The following is a description of a gene set: Catalysis of the reaction: thioredoxin-dithiol + NADP+ = thioredoxin-disulfide + H+ + NADPH. Mouse Gene Set: GOMF_THIOREDOXIN_DISULFIDE_REDUCTASE_NADPH_ACTIVITY studied in species Mus musculus, and this is the list of marker genes: Txnrd2, Txnrd3, Txndc2, Txnrd1, Selenot, Nxn